The following is a description of a gene set: from publication Kwon H, Thierry-Mieg D, Thierry-Mieg J, Kim HP, Oh J, Tunyaplin C, Carotta S, Donovan CE, Goldman ML, Tailor P, Ozato K, Levy DE, Nutt SL, Calame K, Leonard WJ (PMID 20064451) Interleukin-21 (IL-21) is a pleiotropic cytokine that induces expression of transcription factor BLIMP1 (encoded by Prdm1), which regulates plasma cell differentiation and T cell homeostasis. We identified an IL-21 response element downstream of Prdm1 that binds the transcription factors STAT3 and IRF4, which are required for optimal Prdm1 expression. Genome-wide ChIP-Seq mapping of STAT3- and IRF4-binding sites showed that most regions with IL-21-induced STAT3 binding also bound IRF4 in vivo, and furthermore, revealed that the noncanonical TTCnnnTAA GAS motif critical in Prdm1 was broadly used for STAT3 binding. Comparing genome-wide expression array data to binding sites revealed that most IL-21-regulated genes were associated with combined STAT3-IRF4 sites rather than pure STAT3 sites. Correspondingly, ChIP-Seq analysis of Irf4_/_ T cells showed greatly diminished STAT3 binding after IL-21 treatment, and Irf4_/_ mice showed impaired IL- 21-induced Tfh cell differentiation in vivo. These results reveal broad cooperative gene regulation by STAT3 and IRF4. Genes up-regulated in T cells treated with IL21: 1h versus 6h. studied in species Homo sapiens Human Gene Set: GSE19198_1H_VS_6H_IL21_TREATED_TCELL_UP, and this is the list of marker genes: SPC24, LRP4, ALAS2, TEX36, PLIN1, BIK, OR2C3, OXCT1, TGFA, FCER2 (NCBI Gene Id 2208), FEM1C, HCN4, MYOZ2, SCGB1A1, OPN1SW (opsin 1, short wave sensitive), CNKSR2, GJA5, NCKAP5, SAMSN1, MLX, FAT2, CNBD2, HS3ST2, SULF2, F2RL2, CSDC2, PENK, MEIOB, TSPAN8, TAS1R1, CUL9, GPR55, PPP1R3C, HOXA1, LHX8, CARNS1, OR5H1, PKP1, MKNK1, ASB9, RALGPS1, CDH9, DNPH1, PTPRZ1, CD36, SNX13, TMEM235, BLTP2, OR1I1, PHYHIPL, SGK1, CMKLR1, HNF1A, CWH43, EEPD1, STAG3, PRSS30P, HTR2A, OGN, ARHGAP26, MYBPH, WDFY3-AS2, VCAM1, VSNL1, SLC5A2, TBC1D30, PAK6-AS1, KLHDC8A, PPP1R10, MEDAG, C5orf47, PXT1 (NCBI Gene Id 222659), POTEM, LIMCH1, LINC02685, TENT4B, PKP4-AS1, SLC10A4, PLPPR4, ZIC4, C12orf75, FAR2P2, PCAT18, IL18BP, MMP12, SH2D4B, MMP24, OAS1 (NCBI Gene Id 4938), MAS1, MIR9-2HG, ANKRD36BP2, SPMAP2, IFNA21, B3GAT1, DLGAP3, C8orf34-AS1, MAP3K19, NRG3, LYPD3, FAM181A-AS1, ETV5, ACKR1, SLC22A18AS (SLC22A18 antisense RNA), FAM78B, TBC1D27P, MIR3976HG, ABCA9, OGDH, CD1A, SLC12A5, GCNT4, HOTTIP, EDN1, SHISA2, SMG7-AS1, PCM1, PCDH11X, CFP, ENSG00000291065, PDZK1, GCGR, NKX2-2, WDR81, PLSCR4, AKAP12, MCF2, NRCAM, PP2D1, NTNG2, GLIS1, HSD17B3, CHRDL1 (chordin like 1), TBL1Y, GREM1, CNN3-DT, ZNF28, POLR1A, NUDT16-DT, CFAP90, SERPINB5, SCUBE3, BIRC6, ULK2, ROR1, TRAJ17, BAALC-AS2, GADD45A, AQP5, PVRIG, KRT82, RBPJL, CPLANE1, GFM1, GPR52, RGS1, CERNA1, CPEB1, PTTG3P, CELF2, B3GALT5, LINC00163, PREX2, SEMA7A, GALNT5, PRR9, CCKAR, ZNF43, SH3GL2, FOXF1, WNT11, RGL1, BHLHE22, SP6, NAT8, CBX6, IKBKG, HSD11B1, SPATA3-AS1, LRATD1, HAPSTR2, APOBEC3B, RIMS3, FCAMR, NT5C1B, SECTM1, GNAL, NKX6-2, CAMKK1